The following is a description of a gene set: species: Mus musculus Cytokines mediate cell-cell communication in the immune system and represent important therapeutic targets. A myriad of studies have highlighted their central role in immune function, yet we lack a global view of the cellular responses of each immune cell type to each cytokine. To address this gap, the authors created the Immune Dictionary, a compendium of single-cell transcriptomic profiles of more than 17 immune cell types in response to each of 86 cytokines (>1,400 cytokine-cell type combinations) in mouse lymph nodes in vivo. A cytokine-centric view of the dictionary revealed that most cytokines induce highly cell-type-specific responses. For example, the inflammatory cytokine interleukin-1β induces distinct gene programmes in almost every cell type. A cell-type-centric view of the dictionary identified more than 66 cytokine-driven cellular polarization states across immune cell types, including previously uncharacterized states such as an interleukin-18-induced polyfunctional natural killer cell state. Mouse Gene Set: CUI_NK_CELL_IL2_RESPONSE_UP Genes positively differentially expressed in cell type: NK cell upon treatment with cytokine: IL-2 in mouse lymph nodes in vivo. from publication Cui A, Huang T, Li S, Ma A, Pérez JL, Sander C, Keskin DB, Wu CJ, Fraenkel E, Hacohen N (PMID 38057668), and this is the list of marker genes: Flt3l, Uck2, Hcfc1, Atp5mk, Mphosph10, Cish, Ddb1, Prps1, Pus1 (NCBI Gene Id 56361), Psme2, Cluh, Mdh2, Utp15, Romo1, Snd1, Nup54, Eif3i, Hnrnpd, Eef1g, Polr1d, Kti12, Pfdn2, Eif2s2, Tgfb1, Slc29a1, Lyar, Cct5, Uqcc4, Cetn3, Sub1, Mrpl4 (mitochondrial ribosomal protein L4), Ddx39a, Larp1, Mrpl21, Heatr1, Psmd1, Trmt112, Septin11, Ranbp1, Eif2s3x, Eif3j1, P4hb, Nop56, Nopchap1, Hsp90aa1, Tcp1, Lars1, Afg2a (NCBI Gene Id 97062), Lman1, Cdk6, Rrp9, Cyc1, Znrd2, Cct8, Wdr12, Magohb, Mrpl20, Gnb1, C1qbp, Ppan, Nifk, Alyref, Nup210, Tmem11, Rras2, Hnrnpa0, Cad, Agpat5, Gzmb, Nom1, Mrpl54, Nedd8, Polr3d, Pes1, Nudt3, Mydgf, Pim3, Adprs, St13, Mrpl33, Cox5a, Top1, Nab1, Gapdh, Aebp2, U2af2, Polr3e, Smarcb1, Comtd1, Hmgn1, Rwdd1, Fam162a, Gadd45g, Sbno1, Nucks1, Sdf2l1, Krtcap2, Prmt7, Nufip1, Ldha, Brix1, Stt3a, Cpsf2 (NCBI Gene Id 69935), Psmb4, Nars1, Skic3, Hspe1, Srsf9, Ndufa4, Cotl1, Slc35a4, Ssrp1, Kdelr2, Eif3l (eukaryotic translation initiation factor 3, subunit L), Psmb5, Eif2s1, Rbm28, Abce1, Tubb4b, Snrpd3, Ube2i, Set, Rexo2, Pole4, Pole3, Mrto4, Ung, Eif4e, Tars1, Nop16, Cops7a, Rwdd4a, Ola1, Eci1, Pepd (peptidase D), Eif4g1, Pusl1, Hpf1, Dnajb11, Slc25a5, Lrrc59, Chd1, Cct3, Cdc34, Rnf7, Rpn1, Nsun5, R3hdm1, Lsm3, Agpat3, Serpinb9, Ilf2, Eif2b3, Mthfd1l, Psmd12, Mapkapk2, Calr, Cdv3, Sod2, Farsa, Ddx27, Surf4, Dpy19l1, Stk39, Sf3a2, Adamts14, Emc6, Nme1, Uchl3, Ptma, Eif1a, Nr2c2ap, Tmed2, Clpp, Mrps12, Sec13, Ppat, Map4k1, Mrps10, Fam136a, Bid, Rrs1, Snrpe (NCBI Gene Id 99137), Strap, Cdk4, Arf1, Tnpo1 (transportin 1), Wdr18, Nek6, Psma7, Mthfd1, Irf8, Ebna1bp2, Zfp593, Yrdc, Utp20, Rsl24d1, Lrpprc, Ddx54 (NCBI Gene Id 71990), Snrpd2, Nasp, Mrps28, Psme1, Ndufaf4, Pus3, Prmt1, Timm10, Cebpz, Noc4l, Prdx1, Aasdhppt (NCBI Gene Id 72130), Ccnd2, Gart, Hspa9, Stip1, Vma21, Gcsh, Lsm12, Dtx1, Pabpc1, Jaml, Dkc1, Pdia3 (NCBI Gene Id 18794), Timm8a1, Wdr83os, Pa2g4, Rnf126, Nudt5, Pals2, Timm13, Hsp90ab1, Mrfap1, Snrnp27, Mgat2, Kmt5a, Psmb2, Bola2, Yars1, Klrb1a, Luc7l3, Mbd3, Fkbp5, Dpagt1, Ifrd2, Magt1, Exosc8, Npm1, Pdap1, Tmed9, Fcf1 (FCF1 rRNA processing protein), Runx3, Tuba4a, Eny2, Eif5, Hnrnpdl (heterogeneous nuclear ribonucleoprotein D-like), Furin, Spen, Cct7, Pbdc1, Apex1, Bola3, Smarcc1, Noc2l, Timm17a (NCBI Gene Id 21854), Mybbp1a, Nadk, Hnrnpa1, Nhp2, Pam16, Bzw2, Znhit6, Arl1, Ndufb2, Tmem248, Ipo7, Slc39a7, Hnrnpc, Tnfrsf9, Smu1, Ilf3, Wdr46, Prelid3b, Gsto1, Lcp1, Nap1l1, Immt, Carm1, Lap3, Srsf7, Smyd5, Rcl1, Ndufa5, Serbp1, Ltv1, Mrpl17, Mrps26 (NCBI Gene Id 99045), Tubb5, Naa15, Utp6, Abcf1, Cycs, Hint1 (NCBI Gene Id 15254), Tmem238, Hspa8, Sf3b3, Eif5b (eukaryotic translation initiation factor 5B), Pelp1, Creld2, Bop1, Sec61b, Ipo5, Hnrnpm, Ndufa12, Morf4l2, Chchd4, Nsfl1c, Imp4, Uqcr11, Psma6, Wdr75, Cdca7, Snrpa1, Tma16, Ntmt1, Tmed5, Socs1, Psma5, Atp5f1d, Uqcr10, Psma4, Kpnb1, Pgk1, Pdcd11, Scap, Rcc2, Snrpa, Tomm40, Prpf40a, Odc1, Hnrnpr, Shmt1, Eef1e1, Eloc, Gorasp2, Elovl1, Polr2k, F2r, Adss1, Ssr4, Cbfb, Manf, H13, Ppp1r14b, Ssr1, Smyd2, Slc35b1, Myl12a, Eif1, Hnrnpab, Gmfb, Naa10, Rhoq, Exosc3 (NCBI Gene Id 66362), Caprin1, Acaca, Slc39a6, Cmss1, Eif3c, Ube2v2, Pycr3, Aen, Fabp5, Ruvbl1, Kri1, Aimp2, Hnrnpa3, Selenos, Ivns1abp, Ccdc115, Pwp1, Nop2, Phb1, Ppp1r15b, Ube2n, Dph3, Gemin5, Emg1, Eif4b, Cnbp, Pdia4, Utp18, Syce2, Polr1e, Tardbp (NCBI Gene Id 97174), St6galnac4, Bax, Telo2, Mrpl3, Ubap2l, Npm3, Chsy1, Hdgf, Ncdn, Pacsin2, Actg1, Trmt61a, Slc16a6, Tomm20, Mrpl51, Prpf31, Cox7a2, Ncl, Lilrb4b, Aimp1, Ssbp1, Prpf19, Rpia, Grwd1, Rsl1d1 (ribosomal L1 domain containing 1), Kcnq1ot1, Osm, Siva1, Hars1, Akt1, Lsm2, Galk1, Serp1, Ide, Sec61g, Anp32e, Gimap7, Rbm8a, Sar1b, Ndufab1, Paics, Wdr36, Txnl4a, Huwe1, Naa50, Nol8, Pgls, Wdr43, Hprt1, Nudt21, Taf1d, Cmpk1, Prmt5, Eif3a, Aim2, Exosc1, Psmc5, Ino80 (NCBI Gene Id 76476), Atp5pf, Tmed10, Ttc27, Mif, Ybx3, Taf10, Emc7, Fpgs, Atp5f1b, Slc16a1, Polr2f (polymerase (RNA) II (DNA directed) polypeptide F), Cct2, Adh5, Tmem147, Plaa, Vars1, Phf5a, Mrps7, Ran, Mrpl2, Cct4, Bspry, Slc25a39, Zranb2, Btbd1, Canx (calnexin), Pfdn6, Thap12, Erh, Coro2a, Bysl, Impdh2, Psma3, Hspa4, Xpot, Hspd1, Bcap29, Rpf2, Thyn1, Slc7a1, Txnl1, Ddx3x, Dpy30, Eif4h, Rbm3, Fubp1, Mrpl19, Srsf3, Ube2s, Gar1, Kpna1, Htatsf1, Irak1, Drap1, Hspa5, Cfdp1, Lta, Prag1, Ssb, Denr, Snrpf, Glrx3, Atic, Rars1, Utp14a, Mthfd2, Ifng, Aprt, Nop10, Ftsj3, Tfap4, Cfl1, Clns1a, Tle3, Abhd11, Ppp5c, Pprc1, Snrpb (small nuclear ribonucleoprotein B), Rbmxl1, Rbm27, Pdia6, Bccip, Utp25, Arglu1, Elmo1, Szrd1, Dctd, Ppig, Tcea1, Psmd7, Rrp1b, G3bp1 (G3BP stress granule assembly factor 1), Adsl, Esf1, Tex2, Dnajc11, Gramd4, Ptges3, Lsm6, Srsf1, Atp5pb, Ndufc2, Pkm, Phb2, Pum1, Snhg6, Psme3, Ncbp2, Mrpl12, Smarca4, Memo1, Exosc5, Snx3, Mat2a, Usp34, Alkbh1, Fxn, Fbxw8, Mia2, Rad23a, Polr2h, Btf3, Larp4, Ddx21, Hnrnpk, Dtymk, Cox7b, Il2rb, Pomp, Rangap1, Nsun2, Tpi1, Ythdf2, Metap2, Tmem259, Tbl3, Ybx1, Gnl3, Mak16, Rbm25, Umps (NCBI Gene Id 73572), Uqcrq, E2f4, Srsf6, Llph, Syncrip, Anapc15, Atad3a (NCBI Gene Id 71964), Lsm7, Nudcd2, Camkk2 (calcium/calmodulin-dependent protein kinase kinase 2, beta), Clptm1l, Ppia, Pum3, Tmem167, Srsf10 (NCBI Gene Id 14105), Ddx18, Ddost, Eif5a, Nudc, Mrpl23, Hsp90b1, Gnl1, Zfp706, Rae1, Cyb5b, Prf1, Tcerg1, Tfdp1, Banf1, Txn2, Dazap1, Nomo1, Ganab, Srsf2, Tomm5, Stoml2, Mrpl42, Sdad1, Slamf7, Nus1, Mdn1, Grpel1, Parl, Tuba1b, Setbp1 (SET binding protein 1), Cox6a1, Ywhae, Gzma, Nol10, Eif1ax, Uqcc2, Fasn, Snu13, Ak6, Gtpbp4, Ctps1, Pfdn4 (prefoldin 4), Tkt, Mogs, Magoh, Nle1, Smndc1, Atp5mc1, Slc52a2, Prmt3, Mrpl52, Ewsr1, Drg1, Nol6, Dhx15, Ube2l3, Fkbp1a, Tuba1c, Snrpd1, Slc6a6, Bzw1, Shmt2, Isyna1, Iars1, Hsd17b12, Pim2, Ppa1, Cers2, Eno1, Mrpl16, Cacybp, Phgdh, Eif3d, Nop58, Psmc2, Tcof1, Ifrd1, Ankib1, Prkar2a, Uxt, Timm9, Rbbp7, Dctpp1, Psmd11, Etf1, Xbp1, Abcf2, Eif4a1, Fkbp4, Mesd, Prdx6, Eprs1, Fkbp2, Pabpc4, Atp1a1, Mrpl36, Rrp12, Trmt6, Fbl, Ndufb6, Pus7, Hnrnpa2b1 (heterogeneous nuclear ribonucleoprotein A2/B1), Atp5mc3, Ubfd1 (ubiquitin family domain containing 1, NCBI Gene Id 28018), Hnrnpu, Gpatch4, Polr1g (RNA polymerase I subunit G), Bmi1, Mrps24, Pcbp1, Gnpnat1, Sf3a3, Hdlbp, Rif1 (NCBI Gene Id 99400), Eif4g2, Spcs3, Pfn1, Ccdc86, Gspt1, Ddx10, Dcaf1, Dnajc2, Atp2a2, Acbd6, Chchd1, Rbx1, Zdhhc21, Dad1, Ndufb4, Ywhab, Txn1, Mrpl38, Rrp15, Psmd3, Pgam1, Tufm, Polr2l, Xcl1, Srm, Spcs2, Mrps15, Mrps17, Hmbs, Mrps14, Isg20l2, Rrp1, Tpm3, Slc1a5, Eif3b, Snhg12, Pebp1, Ppid, Atad1, Nip7, Slc19a1, Glrx5, Psmc1, Ubl4a, Mrpl15, Nat10, Ppp2r2a, Idh3a, Mtdh, Tsr1, Hypk, Pgd, Mrpl57, Mettl1, Ostc, Erap1 (NCBI Gene Id 80898), Rheb, Dhx33, Suclg2, Mettl16, Nolc1, Mllt6, B4galt5, Pno1, Npepl1, Kars1, Sfxn1, Hyou1, Anp32b, Timm50, U2af1, Vasp, Kdm6b, Uchl5